Given this list of marker genes SMG1, NRP1, ABCC9, FSHR, SH3BGR, PRM1 (protamine 1), RASGRP2, ARHGEF6, CCN5, DHRS3, EGR3, PMP22, DLX6, NPFFR1, KLK14, CD52, GABRR1, TSPAN5, ATP9A, RGS12, CNR1, NR4A1, KLF9, ST8SIA5 (ST8 alpha-N-acetyl-neuraminide alpha-2,8-sialyltransferase 5), MMP1, GHR, NPY1R, ADAM19, CD44, PRELP, GRM7, ZNF141, PDE4D, INSL5, ZFPM2, MMP3, CHST1, GFRA3, MYH1, MYH4, IMPG2, OPRL1, DNM1, SNTG2, PRB4, TFR2 (NCBI Gene Id 7036), MAP2K2, TYRP1, EFNA3, GRK2, RAD23B, CASP1, MYH2, CALCA, SVIL, ALDH1A3, TGFBR3, ACYP1, SERPINA10, CXCR4, ADAMTS3, HTR2B, MMP9, MYO1D, THBS4, E2F1, GCGR, RGS5, OGN, ZFX, ZNF236, MAFB, TMPRSS4, NET1 (neuroepithelial cell transforming 1), CCL2, CDH2, NTRK2, TWF1, SERPINI1, CKB, ACHE, TNFAIP3, SPN, MOBP, A2M, TFPI2, PDE10A, PPP2R2B, NR4A3, GLUL, GPR88, MSX2, FGFR1 (NCBI Gene Id 84151), THBS2, ADAM20, ADH1C, ST3GAL1, RDH5, PTGS1, NOX1, MGLL, here is a description of the gene set: species: Homo sapiens Human Gene Set: KANG_IMMORTALIZED_BY_TERT_DN Expression of TERT, the catalytic protein subunit of the telomerase complex, can be used to generate cell lines that expand indefinitely and retain multilineage potential. We have created immortal adipose stromal cell lines (ATSCs) by stably transducing nonhuman primate-derived ATSCs with a retroviral vector expressing TERT. Transduced cells (ATSC-TERT) had an increased level of telomerase activity and increased mean telomere length in the absence of malignant cellular transformation. Long-term culture of the ATSC-TERT cells demonstrated that the cells retain the ability to undergo differentiation along multiple lineages such as adipogenic, chondrogenic, and neurogenic. Untransduced cells demonstrated markedly reduced multilineage and self-renewal potentials after 12 passages in vitro. To determine the functional role of telomerase during osteogenesis, we examined osteogenic differentiation potential of ATSC-TERT cells in vitro. Compared with naive ATSCs, which typically begin to accumulate calcium after 3-4 weeks of induction by osteogenic differentiation medium, ATSC-TERT cells were found to accumulate significant amounts of calcium after only 1 week of culture in osteogenic induction medium. The cells have increased production of osteoblastic markers, such as AP2, osteoblast-specific factor 2, chondroitin sulfate proteoglycan 4, and the tumor necrosis factor receptor superfamily, compared with control ATSCs, indicating that telomerase expression may aid in maintaining the osteogenic stem cell pool during in vitro expansion. These results show that ectopic expression of the telomerase gene in nonhuman primate ATSCs prevents senescence-associated impairment of osteoblast functions and that telomerase therapy may be a useful strategy for bone regeneration and repair. Down-regulated genes in the signature of adipose stromal cells (ADSC) immortalized by forced expression of telomerase (TERT). from publication Kang SK, Putnam L, Dufour J, Ylostalo J, Jung JS, Bunnell BA (PMID 15579653)